Given this list of marker genes C1qbp, Ifi214, Aars2, Ubqln1, Itch, Ptpn22, Irgm2, Ifi206, Nploc4, Spsb3, Cptp, Trim11, Irgm1 (NCBI Gene Id 15944), Zdhhc18, Pcbp2, Rnf170, Ppp6c, Erbin, Akt1, Ifi213, Banf1, Ptprs (NCBI Gene Id 19280), Cgas, Ifi208, Gramd4, Ifi203-ps, Tkfc, Ifi203, Abhd17a, Dhx58, Ifi209, Mefv, Ppt1, Trim30a, Zdhhc12, Ufd1, Tnfaip3, Riok3, Nlrx1, Fbxl2, Ogt, Aurkb, Lyplal1, Parp1, Tspan6, Prkdc, Igtp, Tarbp2, Hspa8, Smpdl3a, Rnf125, Tax1bp1, Csnk1a1, Gpatch3, Sec14l1, Sirt2, Trex1, Trim31, Znrf4, Ifi207, Mndal, Trem2, Nlrc3, Lamp2, F2rl1, Rab7b, here is a description of the gene set: Any process that stops, prevents, or reduces the frequency, rate or extent of the series of a cytoplasmic pattern recognition receptor signaling pathway. Mouse Gene Set: GOBP_NEGATIVE_REGULATION_OF_CYTOPLASMIC_PATTERN_RECOGNITION_RECEPTOR_SIGNALING_PATHWAY studied in species Mus musculus